Given this list of marker genes SQOR (sulfide quinone oxidoreductase), SPINK1, CKB, AKR1B10, CEMIP, CXCR4, AKR1B1, SYT13, GRB10, here is a description of the gene set: From the conditioned medium of the human colon carcinoma cells, HT-29 5M21 (CM-5M21), expressing a spontaneous invasive phenotype, tumor-associated trypsin inhibitor (TATI) was identified and characterized by proteomics, cDNA microarray approaches and functional analyses. Both CM-5M21 and recombinant TATI, but not the K18Y-TATI mutant at the protease inhibitor site, trigger collagen type I invasion by several human adenoma and carcinoma cells of the colon and breast, through phosphoinositide-3-kinase, protein kinase C and Rho-GTPases/Rho kinase-dependent pathways. Conversely, the proinvasive action of TATI in parental HT29 cells was alleviated by the TATI antibody PSKAN2 and the K18Y-TATI mutant. Stable expression of K18Y-TATI in HT-29 5M21 cells downregulated tumor growth, angiogenesis and the expression of several metastasis-related genes, including CSPG4 (13.8-fold), BMP-7 (9.7-fold), the BMP antagonist CHORDIN (5.2-fold), IGFBP-2 and IGF2 (9.6- and 4.6-fold). Accordingly, ectopic expression of KY-TATI inhibited the development of lung metastases from HT-29 5M21 tumor xenografts in immunodeficient mice. These findings identify TATI as an autocrine transforming factor potentially involved in early and late events of colon cancer progression, including local invasion of the primary tumor and its metastatic spread. Targeting TATI, its molecular partners and effectors may bring novel therapeutic applications for high-grade human solid tumors in the digestive and urogenital systems. from publication Gouyer V, Fontaine D, Dumont P, de Wever O, Fontayne-Devaud H, Leteurtre E, Truant S, Delacour D, Drobecq H, Kerckaert JP, de Launoit Y, Bracke M, Gespach C, Desseyn JL, Huet G (PMID 18317448) Genes up-regulated in constitutively invasive HT-29 5M21 cells (colon cancer) vs the parental non-invasive cells. studied in species Homo sapiens Human Gene Set: GOUYER_TUMOR_INVASIVENESS